Given this list of marker genes Paf1, H2bc8, Ube2w, Ube2a, Ube2n, H2bc6, Wac, Pex2, Pcna, H2bc22, Ube2g1, H2bc12, Prkdc, Uba6, Ube2h, Leo1, Uchl3, Rad18, Hltf, Pex12, Pex10, Rraga, H2bc9, Pex13, Usp5, Rnf152 (NCBI Gene Id 320311), Ube2z, Ubb, H2bc3, Skic8, Ube2k, Pex14, H2bc11, Ube2b, Bcl10, H2bc4, Rnf181, Ube2r2, Cdc34 (NCBI Gene Id 216150), Ube2d2a, Shprh, Uba1, Ube2v2 (NCBI Gene Id 98028), H2bc13, Cdc73 (NCBI Gene Id 96910), Ube2e1, Ube2q2, Otulin, Uba52rt, Rnf144a, Rnf40, H2bc23, Ube2e3, Ube2d1, Rnf20, H2bc1, Ubc, Ube2d3, Pex5, Ube2s, Ube2g2, Uba52, Usp9x, Ube2c, Ube2l3, H2bc14, H2bc24, Rps27a, H2bc21, H2bc7, Ube2t, H2bc15, Ctr9, Usp7, here is a description of the gene set: Protein ubiquitination Mouse Gene Set: REACTOME_PROTEIN_UBIQUITINATION studied in species Mus musculus